The following is a description of a gene set: Mouse Gene Set: WP_MIR302367_PROMOTING_CARDIOMYOCYTE_PROLIFERATION miR302-367 promoting cardiomyocyte proliferation species: Mus musculus, and this is the list of marker genes: Mir302d, Mir302b (NCBI Gene Id 723948), Mst1, Mir302c (NCBI Gene Id 723835), Mob1b, Yap1, Lats2 (NCBI Gene Id 50523)